Given this list of marker genes NFYC (nuclear transcription factor Y subunit gamma), ING2, NFYB, NFYA, CEBPZ, here is a description of the gene set: studied in species Homo sapiens A heteromeric transcription factor complex that binds to the CCAAT-box upstream of promoters; functions as both an activator and a repressor, depending on its interacting cofactors. Typically trimeric consisting of NFYA, NFYB and NFYC subunits. In Saccharomyces, it activates the transcription of genes in response to growth in a nonfermentable carbon source and consists of four known subunits: HAP2, HAP3, HAP4 and HAP5. Human Gene Set: GOCC_CCAAT_BINDING_FACTOR_COMPLEX